The following is a description of a gene set: Genes upregulated in subsets of cells of a given type within various tumors In this study, an extensive analysis was conducted to define meta-programs (MPs) capturing intra-tumor heterogeneity across a spectrum of tumor types. The approach utilized non-negative matrix factorization (NMF) to analyze each cell type separately within individual tumor samples. This involved the analysis of malignant cells, macrophages, fibroblasts, endothelial cells, epithelial cells, T-cells, and B-cells. NMF was executed with varying parameter values (K=4, 5, 6, 7, 8, 9), thereby generating 39 programs for each cell type per sample. Each NMF program was summarized by the top genes based on NMF coefficients.\nRobust MPs were then delineated for each cell type using a set of stringent criteria, including recurrence within the same tumor, similarity to programs in other tumors, and non-redundancy within a tumor. Subsequently, these robust NMF programs were clustered (per cell type) based on Jaccard similarity, leading to the identification of MPs associated with each cell type.\nTo enhance the quality of the MPs, a refinement steps were undertaken, involving the removal of MPs suspected of reflecting low-quality data (with an overrepresentation of ribosomal proteins or mitochondrial-encoded genes), single-study inclusion, or similarity to miss-annotated cell types. studied in species Homo sapiens from publication Gavish A, Tyler M, Greenwald AC, Hoefflin R, Simkin D, Tschernichovsky R, Galili Darnell N, Somech E, Barbolin C, Antman T, Kovarsky D, Barrett T, Gonzalez Castro LN, Halder D, Chanoch-Myers R, Laffy J, Mints M, Wider A, Tal R, Spitzer A, Hara T, Raitses-Gurevich M, Stossel C, Golan T, Tirosh A, Suvà ML, Puram SV, Tirosh I (PMID 37258682) Human Gene Set: GAVISH_3CA_METAPROGRAM_EPITHELIAL_PDAC_RELATED_3, and this is the list of marker genes: MEP1A, UGT2A3, CYP2C18, KRT20, CDHR5, FOLH1, TMPRSS15, DHRS11, MT1G, HPGD, SELENOP, MT1H, TSPAN8, PDK4, SGK1, APOA4, APOA1, TM4SF4, AOC1, SI, ACE2, SLC5A1, SMIM24, ADIRF, APOB (NCBI Gene Id 338), MUC13, HSD17B2, PLAC8, RBP2, ITM2C, CES2, IL32, SLC26A3, PRAP1, CLDN3, CDHR2, PHGR1, TM4SF20, ANPEP, PIGR, PCK1, MTTP, CYP3A4, FABP1, VNN1, FABP2, CDH17, ALDOB, AMN, CD74